The following is a description of a gene set: Genes predicted to be targets of miRBase v22 microRNA hsa-miR-4782-5p in miRDB v6.0 with MirTarget v4 prediction scores > 80 (high confidence targets). Human Gene Set: MIR4782_5P from publication Chen Y, Wang X (PMID 31504780) studied in species Homo sapiens, and this is the list of marker genes: CFLAR, SHISA6, ZNF749, GPATCH11, CHST9, HIPK4, ALAS1, RHAG, PTGER3, PNPLA4, OSTC, IFI6, DCUN1D3, UNC5C, POGZ, CTCF, TOX3, HIGD1A, CAPN12, ATP6V0C, DNMT3A, UBXN10, STRIP1, PKDCC, TBC1D8B, DDI2, SAMD12, BAZ2B, DDAH1, ZFP1, CLEC19A, WDR26, KRBOX4, CSPG5, PGM2, VEGFA, UNC5B, TCTN1 (NCBI Gene Id 79600), PRKG2, TRMT11, NCBP1, CTNNA3, IGF2BP3, FER, VSIG1, P2RX7, RHOQ (NCBI Gene Id 56679), DERL2, RFC3, ADAM29, NFIB, NAA25, ADD3, RPS6KA2, KCNAB1, CHL1, TBX18, RNF6, MYRIP, SOX6, DENND1B, GXYLT1 (NCBI Gene Id 338841), NAB1, KCNMA1, TLN2, CD28, ELOVL3, MAGI3, LNPEP, MTO1, CXXC4, CEP192, RBFOX1, TM9SF3, ALX4, FIGN, ALDH9A1, CRIPT, CEP44, STAG2, NFAT5, UBE2W, SOAT1, AZIN1, DYNC1LI2, ZNF534, CXCL8, GCOM1, KLHL12, ARHGEF12, SLC2A5, PAG1, TMTC4, PATE4, RBM18, PCDH9, PGRMC1, GPR3, CD302, ANKRD17, MIER1, TENM1, MIER3, GALNT15, CDK6, LYPD1, CTAGE1, RYR3, SUMO2, VTI1A, CACNA1E, ZMAT4, SASH1, CAST, GRIA2, SLC26A9 (solute carrier family 26 member 9), RALGAPB, GPR107, CD164, FBXL17, CNOT2, LY75-CD302, ZCCHC7, TMEM255A (transmembrane protein 255A), VSX1, PTGER4 (NCBI Gene Id 5734), TMEM212, TMEM135, ACER3, GYS1, TMOD2, PLEKHA5, GET1-SH3BGR, MAT2B, RPS6KA5, GFOD1, TAF1B, CUX2, PSMB4, CCDC122, PRRX1, WDR48, CALN1, SPOP (NCBI Gene Id 8405), ADGRE2, LHX9, CPEB2, C15orf40, NEU3, ABCC9, CERKL, SH3BGR, EMC7, FNBP1, TSPAN33, MID1IP1, ATXN1, PAK5, RAD23B, PEG10, SMPD3, HOXC10, ZNF778